The following is a description of a gene set: studied in species Mus musculus The process of gaseous exchange between an organism and its environment. In plants, microorganisms, and many small animals, air or water makes direct contact with the organism's cells or tissue fluids, and the processes of diffusion supply the organism with dioxygen (O2) and remove carbon dioxide (CO2). In larger animals the efficiency of gaseous exchange is improved by specialized respiratory organs, such as lungs and gills, which are ventilated by breathing mechanisms. Mouse Gene Set: GOBP_RESPIRATORY_GASEOUS_EXCHANGE_BY_RESPIRATORY_SYSTEM, and this is the list of marker genes: Grin1 (glutamate receptor, ionotropic, NMDA1 (zeta 1)), Nmbr, Stk40, Ap3b1, Man2a1, Jag2, Sftpc, Cfap221, Fut8, Atp1a2, Grpr, Tas2r108 (NCBI Gene Id 57253), Cfap54, Mtg1, Hipk2 (NCBI Gene Id 68602), Chrna4, Man1a2, Slc5a3, Selenon, Nek10, Dnah9, Fkrp, Glra1, Ttll1, Phox2a, Nmb, Grp, Nr4a2, Col6a1, Dach1, Spag16, Ndufs4, Drc1, Fto, Adora1, Nlgn2, Ndn, Edn1, Tshz3, Tcf15, Nlgn1, Gaa, Spef2, Tnnc1, Mtg2, Flt4, Traf4, Pask, Cfap43, Ndst1 (N-deacetylase/N-sulfotransferase (heparan glucosaminyl) 1), Ecel1, Gls, Sftpa1, Nlgn3, Vangl1, Adh5 (alcohol dehydrogenase 5 (class III), chi polypeptide), Hoxa5, Ednra, Zfand5, Odad4, Spag6l, Ccbe1, Tlx3 (T cell leukemia, homeobox 3), Sftpd, Mafb, Kdm6a, Bloc1s6, Hmga1, Dcaf11, Mapk8ip3, Ccdc88c, Hps1, Cc2d1a, Ddit3, Gsx2 (GS homeobox 2), Sftpb, Rab3a (NCBI Gene Id 19339), Ntsr1, Mecp2, Pbx3, Chst11, Ywhaz, Phox2b, Adrb2, Stard7